Given this list of marker genes OPN1MW, RDH12 (retinol dehydrogenase 12), TTR, RBP4, NAPEPLD, RLBP1, OPN1SW, STRA6, RDH5, OPN1LW, LRAT, ABCA4, RBP1, here is a description of the gene set: part of: Disease Reactome Pathway: Diseases of the neuronal system species: Homo sapiens Diseases of the neuronal system can affect sensory cells and transmission of signals between sensory cells and sensory neurons, transmission of signals across electrical and chemical synapses in the nervous system, and transmission of signals between motor neurons and muscle cells.<br><br>We have so far annotated diseases of visual phototransduction due to retinal degeneration caused by defects in the genes involved in the retinoid cycle.